The following is a description of a gene set: Any process that decreases the rate, frequency, or extent of a response to cytokine stimulus. species: Mus musculus Mouse Gene Set: GOBP_NEGATIVE_REGULATION_OF_RESPONSE_TO_CYTOKINE_STIMULUS, and this is the list of marker genes: Ythdf3 (NCBI Gene Id 71600), Isg15, Nr1h4, Mapk7, Parp14, Oas1h, Naip6, Oas1e, Mul1, Map2k5, Il1r2, Usp18, Cnot7, Trem2, Cldn18, Oas1f, Oas1b, Apoa1, Traip, Adipoq, Mmp12, Sigirr, Naip5, Gas6, Ttll12, Smim30 (small integral membrane protein 30), Ptprf, Tle5, Gigyf2, Oas1g, Klf4, Oas3, Mavs (NCBI Gene Id 228607), Ccdc3, Nlrc5, Trex1, Arg1, Usp25, Ccl5, Dnaja3, Il1rn, Cav1, Slit3 (slit guidance ligand 3), Stap1, Otud4, Rnf113a1, Rffl, Cactin, Mettl3, Sh2b3, Padi2, Oas1d, Tnfrsf11b, Nol3, Il36rn (NCBI Gene Id 98939), Xiap, Adar, Ppp2cb, Ptprc, F2rl1, Palm3, Peli3, Pias4, Ythdf2, Birc7, Gps2, H2bc21, Oas1c, Rabgef1, Tjp2, Oas1a (NCBI Gene Id 246730), Stat2, Il6, Pparg, Rnf113a2, Ptpn2, Eif4e2 (NCBI Gene Id 98625), Tank, Dcst1, Il6st, Irak3, Cish, Otop1, Naip2, Dicer1, Cyld, Slit2, Robo1, Samhd1, Ecm1, Naip1